The following is a description of a gene set: studied in species Homo sapiens Human Gene Set: GOBP_URATE_METABOLIC_PROCESS The chemical reactions and pathways involving urate, the anion of uric acid, 2,6,8-trioxypurine, the end product of purine metabolism in certain mammals and the main excretory product in uricotelic animals., and this is the list of marker genes: PRPS1, URAD, SLC17A3, GCKR, SLC22A12, SLC16A9, PNP, SLC22A11, SLC17A1, SLC2A9, ABCG2, G6PC1, CARMIL1